The following is a description of a gene set: Any process that modulates the frequency, rate or extent of osteoblast proliferation. Mouse Gene Set: GOBP_REGULATION_OF_OSTEOBLAST_PROLIFERATION species: Mus musculus, and this is the list of marker genes: Sox8, Mn1, Rhoa, Tnn, Axin2, Grem1, Fbln5, Nell1, Atraid, Fgfr2, Itgav, Itgb3, Cthrc1, Gata1, Bcl2, Eif2ak2, Smad3, Ccn1, Lrp5, Igf1r, Npr3, Gsk3b, Bmp2 (NCBI Gene Id 98992), Nf2, Abl1, Ahr, Ltf, Sfrp1, Tmem119, Plxnb1, Hpse